Given this list of marker genes POR, DHX34, MAN2C1, TYROBP, ESAM, MSN (NCBI Gene Id 4478), HS3ST2, ACTR1B, VSTM4, SUOX, RIPK2, GPX4, ARHGAP9, AQR, UVSSA, TBX20, E2F7, DYNLT2B, FOXD2, EMILIN2, FILIP1L, PHACTR3, PLD1, EPC2, RSAD2, TGM4, SMG1 (NCBI Gene Id 23049), IFIH1, KXD1, TIMD4, FAM111A, HCFC1R1, LLGL1, ANKRD37, PLXNC1, CTSD, CRBN, HS1BP3, GPRC5D, SNRNP48, STMN1, C2orf88, CYRIA, SLC38A5, HEXB, YAP1, PIP4K2A, SEL1L3, BTBD8, CADM3, EMC1, RNF38, ZDHHC6, TOB1, NOBOX, TRIM56, TMLHE, ACKR1, IGFLR1, NFKBIE, GAREM1, LNX1, POLB, CD2BP2, ESRRG, INCENP, PLA2G7 (phospholipase A2 group VII), TBC1D10C, CA2, CD4, USF2, MPLKIP, SLC2A13, TMEM132A, MTUS1, PLXNB2, TBC1D32, TSPYL2, DYRK2, XRCC3, RPRD2, ZMIZ2, HACD4, AKAP13, TCN2, RCL1, KIF13A, DHRS3, PTPN12, MRGPRE, GGA2, LIMD2, CHRNE (cholinergic receptor nicotinic epsilon subunit), GLIS2, TENT5A, PIK3R3, ENC1, FRMD5, GBA2, NPTX1, SLBP, BRD9, LMO2, SLFN13, HMGN5, D2HGDH, GOT1L1, SYNGR3, ST8SIA1, CD69, SIRPA, FAM43A, TRIM8, CST7, RGL1, TNIP1, EIF4E3, ZNF296, CLMP, EHF, TRIM34, ABHD12, DMAC2, SERPINB7, CEP126, CAPSL, RRP9, CD300LB, CEP83-DT, XAF1, CLPB, DAPP1, ST3GAL6, MAP4K3, TET2, MKRN1, CDC42EP3, SCNN1G, RDM1, KLRG1, LTO1, PILRB, NMU, IFT80, TNIK, WDFY2, PDE4DIP, CDK20, OGA, CYFIP1, ENTPD4, TEF, YIPF4, TNFAIP8, ZNF532, WASHC2A, AKAP8, UTF1, KCNC2, SGO2, CACNG7, PHF21A, S100PBP, NEO1, SVIP, CDC7, ACTN4, CERKL, THRAP3 (thyroid hormone receptor associated protein 3), PCYT1A, HLA-DMB, GPT, SLAIN2, LGALS8, MAP7D1, NRGN, PINK1, SLC30A10, KIT, CCNE1, ATP13A3, PTPRC, TSPAN14, VAV2, ADA, PCM1, SELP, LY86, ALPI, SUCO, SMPD4, GABBR1, GSG1, OSBPL7, CNOT2, TRAF3, LYN, RGS7, RNF114, SLC6A12, here is a description of the gene set: Th1 and Th2 cells arise from a common precursor cell in response to triggering through the TCR and cytokine receptors for IL-12 or IL-4. This leads to activation of complex signaling pathways, which are not known in detail. Disturbances in the balance between type 1 and type 2 responses can lead to certain immune-mediated diseases. Thus, it is important to understand how Th1 and Th2 cells are generated. To clarify the mechanisms as to how IL-12 and IL-4 induce Th1 and Th2 differentiation and how TGF-beta can inhibit this process, we have used oligonucleotide arrays to examine the early polarization of Th1 and Th2 cells in the presence and absence of TGF-beta after 0, 2, 6 and 48 hours of polarization. Genes down-regulated in CD4 T cells activated by anti-CD3 and anti-CD28: IL4 (48h) versus untreated (48h). from publication Lund R, Aittokallio T, Nevalainen O, Lahesmaa R (PMID 14607935) Human Gene Set: GSE2770_IL4_ACT_VS_ACT_CD4_TCELL_48H_DN studied in species Homo sapiens